Given this list of marker genes MRM2, HENMT1, TRMT13, MRM3, MRM1, FBL, FTSJ3, FTSJ1, BCDIN3D, FBLL1, here is a description of the gene set: Catalysis of the reaction: S-adenosyl-L-methionine + RNA = S-adenosyl-L-homocysteine + RNA containing 2'-O-methylribonucleotide. studied in species Homo sapiens Human Gene Set: GOMF_RNA_2_O_METHYLTRANSFERASE_ACTIVITY